Given this list of marker genes TLR2, PTAFR, SCARB1, LY96 (NCBI Gene Id 23643), TLR4, CD14, here is a description of the gene set: Human Gene Set: GOMF_LIPOPOLYSACCHARIDE_IMMUNE_RECEPTOR_ACTIVITY species: Homo sapiens Combining with a lipopolysaccharide and transmitting the signal across the cell membrane to initiate an innate immune response. Lipopolysaccharides (LPS) are major components of the outer membrane of Gram-negative bacteria, making them prime targets for recognition by the immune system.